Given this list of marker genes Gabarap, Inava, Dcun1d5, Mapk15, Tbc1d7, Ndfip1 (Nedd4 family interacting protein 1), Cav1, Pias1, Uba2, Angpt1 (angiopoietin 1), Prkn, Fam107a, Rnf111, Plk1, Marchf7, Rnf40, Spsb4, Cry1, Trib2, Cblb (NCBI Gene Id 208650), Tank, Arrdc3, Pias3, Traf7 (TNF receptor-associated factor 7), Fbxo4, Pef1, Vcp, Gsk3b, Sprtn, Mastl, Ube2srt, Ubqln1, Derl1, Arrdc4, Wbp1l (WW domain binding protein 1 like), Ube2v2, Birc7, Sphk1, Peli1, Gsk3a, Ube2v1, Axin1, Senp2, Btrc, Ripk2, Lrrk2, Trib3, Amer1, Fancm, Egr1, Cdc20, Hspa5, Huwe1, Fbxo33, Klhl40, Fgfr3, Ube2d1, Tspyl5, Mapk8, Nmi, Dcun1d2, Cd300ld3 (NCBI Gene Id 382551), Fbxw7, Ubb, Mul1, Topors, Nop53, Wfs1, Dnajb2, Hamp2, Commd1, Xiap, Cdc14b, Pias4, Cdk5rap3, Bmi1, Ddx3x, Arnt (aryl hydrocarbon receptor nuclear translocator), Hspbp1, Hdac4, Rasd2 (RASD family, member 2), Ngf, Arrb1, Rbx1, Mycbp2, Pttg1ip, Cul3, Ahrr, Paxip1, Rchy1, Mapk9, Npm1, Ube2n, Fzr1, Dcun1d4, Tes3-ps, Skp2, Stub1, Birc5, Ndfip2, Pten, Nsmce3, Nod2, Cdkn2a, Hamp, Mta1, Skp1, Fanci, Tollip, Aimp2 (aminoacyl tRNA synthetase complex-interacting multifunctional protein 2), Ptpn22, Phf23, Septin4, Tm9sf5, Ube2l3, Prickle1, Rwdd3, Rassf5, Ube3a, Rassf1, Birc3, Trib1, Tnip1, Rps2, Dcun1d3, Birc2 (baculoviral IAP repeat-containing 2), Rbx1-ps, Laptm5, Sumo2 (NCBI Gene Id 235709), Chfr, Ticam1, Psmd10, Gnl3, Sae1, Bcl10, Dnaja3, Rnf180, Nscme3l, Ube2s, D1Pas1, Kdm1a, Pdcd6, Zc3h12a, Dcun1d1, Nhlrc1, Hdac3, here is a description of the gene set: Any process that activates or increases the frequency, rate or extent of post-translational protein modification. Mouse Gene Set: GOBP_POSITIVE_REGULATION_OF_POST_TRANSLATIONAL_PROTEIN_MODIFICATION species: Mus musculus